Given this list of marker genes CYP1A2 (NCBI Gene Id 1544), CYP3A5, CYP2D6, CYP3A43, CYP3A4, ALKBH1, CYP2C9, CYP2C8 (cytochrome P450 family 2 subfamily C member 8), CYP3A7, JMJD6, here is a description of the gene set: species: Homo sapiens The process of removing one or more methyl groups from a molecule, involving the oxidation (i.e. electron loss) of one or more atoms in the substrate. Human Gene Set: GOBP_OXIDATIVE_DEMETHYLATION